The following is a description of a gene set: Mouse Gene Set: GOCC_CYTOSOLIC_RIBOSOME A ribosome located in the cytosol. studied in species Mus musculus, and this is the list of marker genes: Rpl6l, Gm6525, Ppargc1a, Zcchc17, Rps4l, Rps16, Rpsa, Rpl22, Rps27rt, Rpl17 (ribosomal protein L17), Gspt1, Pelo, Rpl4, Rpl3, Rpl23, Rpl32-ps, Rplp0, Rps27, Rps25, Rplp2, Rps15, Rps17, Rpl19, Rpl28, Rpl30, Fau, Rpl10a, Rpl10, Rpl15, Rpl17-ps8, Rps28, Rpl35a, Rpl23a, Rpl32, Eif2d, Rpl7, Rps6-ps4, Rnf10, Rps4x (ribosomal protein S4, X-linked), Ltn1, Rnf25, Rps12, D1Pas1, Rps2, Ascc3, Rpl9-ps1, Rpl10l, Uba52, Mcts1, Rps3, Hbs1l, Rpl34, Rpl24, Rpl34-ps2, Eif2ak4, Rpl8, Rpl37, Rplp2-ps1, Rpl37a, Rps23, Rpl39l, Rpl27a, Rpl13, Rpl29, Rpl7a, Rpl36-ps12, Repin1, Rpl36, Rpl21, Eef1a1, Rpl26, Rpl27rt, Rps11, Rps26, Metap1, Larp4, Rps29, Rps20, Rps9, Nemf, Rps13 (NCBI Gene Id 68052), Etf1, Ascc2, Rpl5, Rpl10-ps3, Rpl35, Rps15a, Rpl11, Rps3a1, Rpl9, Rpl37rt, Dhx29, Zfp598, Rps14, Rps5, Rps10, Rpl18a, Rpl27, Eif2a, Uba52rt, Rps27l, Ddx3x, Rps18, Rps6, Rpl32l, Rpl31, Rpl18, Rnf14, Rpl14, Rplp1rt, Rpl9-ps6, Abce1, Rps24, Rpl36al, Rps7, Gm6133, Rps19, Rpl39, Rpl34-ps1, Rpl41, Rplp1, Rpl7l1, Rpl3l, Rpl6, Rpl36a, Rpl13-ps6, Rpl13a, Gcn1, Rpl12, Rps27a, Usp10, Rpl35rt, Rps8, Rps21, Apod, Rpl38, Uba52-ps